The following is a description of a gene set: Mouse Gene Set: REACTOME_TETRAHYDROBIOPTERIN_BH4_SYNTHESIS_RECYCLING_SALVAGE_AND_REGULATION studied in species Mus musculus Tetrahydrobiopterin (BH4) synthesis, recycling, salvage and regulation, and this is the list of marker genes: Calm2, Akt1, Hsp90aa1, Pts, Calm1, Gch1 (GTP cyclohydrolase 1), Calm3, Gchfr (GTP cyclohydrolase I feedback regulator), Nos3, Spr